Given this list of marker genes ITGA2, SMARCB1, CYP1A1, PROX1, WNT1, PCK2, TAF10, E2F8, CPS1, PCK1, E2F7 (NCBI Gene Id 144455), FRZB, FOXH1, MESP1, here is a description of the gene set: Human Gene Set: GOBP_HEPATOCYTE_DIFFERENTIATION studied in species Homo sapiens The process in which a relatively unspecialized cell acquires the specialized features of a hepatocyte. A hepatocyte is specialized epithelial cell that is organized into interconnected plates called lobules, and is the main structural component of the liver.